The following is a description of a gene set: Any process that results in a change in the behavior of an organism as a result of a nicotine stimulus. Mouse Gene Set: GOBP_BEHAVIORAL_RESPONSE_TO_NICOTINE studied in species Mus musculus, and this is the list of marker genes: Chrna5 (NCBI Gene Id 11439), Htr2c, Chrna3, Chrna4, Chrna6, Chrnb2, Ppara, Chrnb4, Grm2, Chrna7, Chrnb1